The following is a description of a gene set: Human Gene Set: GOBP_TRANS_SYNAPTIC_SIGNALING_BY_LIPID studied in species Homo sapiens Cell-cell signaling from post to pre-synapse, across the synaptic cleft, mediated by a lipid., and this is the list of marker genes: FABP5, CNR1, ABHD6, PLCB1, F2R, FAAH, DAGLA, CNRIP1, CNR2